Given this list of marker genes FGF4, FGFR3, FGF23, FGF18, FGF20, PIK3CA, PIK3R1, GAB1, PTPN11, FGF8, GRB2, FGF9, FGF17, FRS2, FGF5, FGF16, FGF1, FGF2, here is a description of the gene set: Human Gene Set: REACTOME_PI_3K_CASCADE_FGFR3 studied in species Homo sapiens PI-3K cascade:FGFR3